Given this list of marker genes Ufl1, Tlr9, Nedd4, Gphb5, Kcnk13, Slc15a4, Rftn1, Csnk1a1, Esrra, Cptp, Parp1, Rnf135, Esrrb, Nod1, Arid1a, Cnot2, Usp17le, Safb2, Brcc3, Trim68, Dnaja1, Med1, Casp4, Pias2, Nr1h3, Washc4, Nr1h5, Sting1, Cd36, Zdhhc3, Sirt1, Hdac1, Akap13, Nr4a1, Srarp, Oas1c, Smpdl3a, Ddx17, Thrb, Trerf1, Pum2, Trim30a (tripartite motif-containing 30A), Scimp, Oas1h, Esr1, Trim31, Cd86, Vps11, Tifa, Rhoa, Gpatch3, Foxa1, Lsm14a, Hmga1, Pim1, Phb1 (prohibitin 1), Riok3, Huwe1, Nek7, Cst11, Ppt1, Ncoa1, Slc15a2, Mndal, Tspan6, Xiap, Nr3c1, Kdm3a, Gh, Esr2, Sirt2, Banf1, Paqr3, Cgas, Uba5, Flt1, Zfp366, Ifi209, Gps2, Prmt2, Ubr5, Gm15441, Ifih1 (NCBI Gene Id 71586), Gm12250, Trp63, Ddx5, Otulin, Brca1 (NCBI Gene Id 12189), Cry1, Nr0b1, Usp15, Ywhah, Rtn4, Nr5a2, Ufm1, Nodal, Ifi206, Cd300ld3, Kank2, Havcr2, Kdm4c, Ptgis, Safb, Tnip2, Ptf1a, Scgb2a2 (NCBI Gene Id 102639117), Tab1, Hnf4a, D1Pas1, Jak2, Lamp2, Rarg, Twist1, Clpb, Epg5, Nr5a1, Ncor2, Nr1h2 (NCBI Gene Id 381996), Irf3, Alox15, Tasl, Oas1g, Oas1b, Cyp26b1, Trim24, Spsb3, Slc15a3, Hcfc2, Foxp1, Ncor1, Rara, Tnfaip3 (NCBI Gene Id 21929), Ppargc1b, Plcg2, Ipo5, Ufsp2, Stub1, Gper1, Strn3, Btk, Aldh1a3, Cav1, Klf2, Zcchc3, Kcnj8, Rigi, Irf7, Trim11, Ifi213, Gkn2, Lbh, Traf6, Rorc, Nlrp1a, Tax1bp1, Cyp27b1, Ptpn22, Shq1, Phb2, Thra, Atat1, Nfkbia, Ywhae, Dnaaf4, Rab7b, Oas1a, Tkfc, Elp6, Pdk3, Tmf1, Itch, Strap, Pik3ap1 (NCBI Gene Id 83490), Treml4, Asxl2, Pde3a, Nr1i2, Vdr, Rnf6, Trem2 (NCBI Gene Id 83433), Ppp5c, Traf3ip3, Park7, Zdhhc7, Rbfox2, Vps18, Cyp7b1, Nop53, Mark4, Cnot9, Nlrp3, P2rx7, Nlrc3, Pou4f2, Smarca4, Crebrf, Tlr7, Errfi1, Ncoa2, Inava, Snai2, Prkd1, Mapk8, Stmp1, Usp26 (ubiquitin specific peptidase 26), Ifi203, Pagr1a, Pou5f1, Nr1i3, Ifi208, Nr1h4, Srebf1, Gprin3, Kdm5d, Ifi207, Tnf, Clock, Prkdc, Rarb, Rnf125, Zdhhc18 (NCBI Gene Id 503610), Snw1 (NCBI Gene Id 66354), Irf2, Ddx60, Pml, Rxrg, Esrrg, Dhx33, Nr4a2, Bmal1, Fkbp4, Daxx (Fas death domain-associated protein), Ep300, Tlr3, Ppp2ca (protein phosphatase 2 (formerly 2A), catalytic subunit, alpha isoform), Hspa1b, Arnt, Prcp, C1qbp, Kmt2d, Fshr, Tarbp2, Irf1, Crkl, Trim15 (tripartite motif-containing 15), Plin5, Trim25, Eif2ak2, Jund, Ezh2, Ubqln1, Wbp2, Alpk1, Nkx3-1, Pten, Zdhhc9, Oas3, Erbin, Trim3, Nlrx1, Ddrgk1 (DDRGK domain containing 1), Ntrk2, Rwdd1, Sfrp1, Rxrb, Foxh1, Igf1, Mn1, Rora, Gramd4, Nr3c2, Fbxl2, Klf9, Ufd1, Pak1, Oas1d, Aldh1a2, Fabp5, Kmt2e, Nod2, Tcf21, Lyplal1, Ube3a, Nploc4, Tlr13, Pparg, Irgm2, Akr1c18, Tirap (toll-interleukin 1 receptor (TIR) domain-containing adaptor protein), Trip4, Nr1d2, Ncoa3, Zc3hav1, Aurkb, Ifi214, Rnf170, Abhd2, Peli3 (pellino 3), Hspa8, Irgm1, Zfp536, Ppard, Lats1, Gbp2, Nr4a3, Sp1 (NCBI Gene Id 68485), Lacc1, Wdfy1, Aars2, Bdnf (brain derived neurotrophic factor), Ddx3x, Pcbp2, Hmga2, Cnot3, Ogt, Usp50, Oas1e, Slc19a1, Cry2, Ar, Rsad2, Ptges3, Nlrp6, Sec14l1, Isl1, Ghrhr (growth hormone releasing hormone receptor), Map3k7, Taf7, F2rl1, Trex1, Stat3, Ahr, Becn1 (NCBI Gene Id 56208), Nr2f2, Aloxe3, Greb1l, Dhx58, Rxra, Nlrp1b, Cnot1, Pgr, Actn4, Colec12, Heyl, Brcc3dc, Unc93b1, Mavs, Nagk, Akt1, Rela, Padi2, Cited2, Pum1, Abhd17a, Alox8, Cyp26a1, Calcoco1, Tlr6, Igtp, Skp2, Calr, Tbk1, Slc46a2, Tlr4, Fam120b, Ifi203-ps, Pycard, Lats2 (large tumor suppressor 2), Asxl1, Ptprs, Dhrs3, Gbp5, Stard10, Zdhhc1 (NCBI Gene Id 70796), Ankrd17, Rorb, Tlr8, Flot1, Zdhhc12, Tbx1, Zmiz1, Ripk2, Cyp2j6, Znrf4, Myd88, Oas1f, Or51e2, Dab2, Nr2c1, Ctbp2, Oasl1, Ticam1, Peli1, Zbtb7a, Bmp2, Per1, Lep, Rnf14, Tgif1, Hmgb1, Ppara, Src, Carm1, Rnf34, Ppp6c, Zdhhc5, Mapk1 (NCBI Gene Id 98012), Nr1d1 (NCBI Gene Id 97769), Lmo3, Mefv, here is a description of the gene set: studied in species Mus musculus Mouse Gene Set: GOBP_INTRACELLULAR_RECEPTOR_SIGNALING_PATHWAY The series of molecular signals initiated by a ligand binding to a receptor located within a cell.